The following is a description of a gene set: species: Homo sapiens Pathway Definition from KEGG: SERPING1 -| (F11a,F12a,Kallikrein,Plasmin,PLAU,C1R,C1S,MASP1/2) Regulation of fibrinolytic system, C1INH. Pathway ID: N01520. Pathway type: Reference. Pathway class: nt06513 Complement cascade. Human Gene Set: KEGG_MEDICUS_REFERENCE_REGULATION_OF_FIBRINOLYTIC_SYSTEM_C1INH, and this is the list of marker genes: MASP2, MASP1, PLAU, SERPING1, C1R, C1S